The following is a description of a gene set: Mouse Gene Set: chr13A4 studied in species Mus musculus, and this is the list of marker genes: Cd83, Gm32401, Gm26064, Gm33195, 1700061E18Rik, Gm32939, Gm33630, Gm23117, Tbc1d7, Ranbp9, Gm7214, Gm29676, Gm28707, Gm33684, Gm33489, Gm2233, Adtrp, Mcur1, Edn1, Hivep1, Gm32184, Gm47125, Gm5082, Tmem170b, Sirt5, Gm6049, Gfod1, Nedd9, Phactr1, Gm15813, Gm5083, Gm28564, Gm22157, Gm20751, Gm33115, Nol7, Rnf182